The following is a description of a gene set: studied in species Homo sapiens Human Gene Set: REACTOME_NERVOUS_SYSTEM_DEVELOPMENT Nervous system development, and this is the list of marker genes: RPS13, TUBB4A, HRAS, MYH11, RANBP9, CYP51A1, RPL10L, CACNB3, COL9A2 (collagen type IX alpha 2 chain), RPS27L, COL4A5, DCC, LAMB1, PRX, PIK3R2, ARHGAP35, EFNA5, DSCAM, PSMC5 (proteasome 26S subunit, ATPase 5), RPS21 (ribosomal protein S21), COL4A4, MSN, COL4A2, MAGOHB, EPHA5, RPL27A, TRPC7, RPS24, PSMB6, COL6A1, DNM3, TUBA8 (tubulin alpha 8), RPL41, RPL18, SRGAP1, AKAP5, PSMB4, KALRN (kalirin RhoGEF kinase), PAK2, FAU, UNC5D, EPHB1, SHC3, DOK5, UPF2, SPTBN2, NUMB, TUBB2B, SEMA7A, RPS6KA2, KRAS, CUL2, EPHA3, ITGA2, CACNA1C, SH3GL2, PSMD1, CDC42, LIMK1, RPL37A, ROCK2, SCN3B (NCBI Gene Id 55800), GRB7, RPS8, DCX (doublecortin), RPL35A, EFNA1, MYH9, ABLIM1, GJB1, PPP3CB, NTN4, NRAS, RPL3, MYL6, TEAD1, NRTN, RPL27, GRIN1, CNTN2, SCN4A, FLRT3 (fibronectin leucine rich transmembrane protein 3), DSCAML1, PSMD8, ITGA5, HSPA8, SPTBN5, RPS16, PRKACB, RPL37, LHX2, AGRN, RPL17, ENAH, PSMA1, RPLP1, EVL, PSENEN, CFL1, SRGAP3, RPS7, CAP1, RPL8, ITGA9, RPL28, CSNK2A2, TYROBP, RPS2 (NCBI Gene Id 6187), LYN, IRS2, PSMC3, PLXNA1, RPLP2, EPHB2, PSMA4, RPL3L, ROBO3, TUBA1C, CNTN6, SCN1A, RPL9, PRNP, YES1, CACNA1H, DLG3, DAG1, TRPC4, CDK5, EPHA4, PSMB7, PAK6, COL4A1, COL6A6, SOS1, TIAM1, DLG1, MAGOH, RPL7A, SCN11A, PIK3R1, AP2M1, PSMD3, NCBP1, EPHA7, RPL32, PSMD11, GAB2, ROCK1, MAP2K1, PSMC6, SCN2B, PRKACA, TUBAL3, GRB2, PTPRA, RPS4Y2, RPL5, ARHGEF11, TUBA4B, LYPLA2, ABLIM3, SIAH2, SOS2, DPYSL2, ADGRG6, COL9A1, SCN9A, RPS6, ANK2, EGR2, TUBA1A (tubulin alpha 1a), TUBB6, EFNA2, ARPC2, TUBA3C, AP2S1, ARHGEF12, DPYSL3, SEMA3A, CREB1, RPL22L1, MYH14, TUBB8B, TUBB3, RBM8A, ADGRV1, PRKAR2A, CSNK2B, COL6A2, PIK3CA, GFRA3, DOK1, RET, PSMB5, MAPK1, RPS11, NCBP2, LHX4, DOK4, NRP2, PRKACG, SOX10, DPYSL4, ELOC, ANK3, RPL34, PSMC4, GFRA1, FARP2, MYL12A (myosin light chain 12A), PSMB1, FRS2, ARHGEF28, CACNA1S, ARPC4, SCN4B, RGMA, UPF3B, UBA52, CHL1, MSI1, CAP2 (NCBI Gene Id 10486), RPL30 (NCBI Gene Id 6156), COL5A2, WASL, RAP1GAP, VAV2, CACNA1G, LHX3, NCAM1, EFNB1, GAB1, RPL10, TUBB4B, ACTR3, PRKCQ, SEMA3E, SEMA6D, RPLP0, PABPC1, RPL31, TRPC5, PMP22, EPHA6, DOK2, EFNA3, ERBB2, RPL13A, ROBO2, COL6A3, TREM2, TUBB1, VLDLR, KIF4B, WWTR1, TUBB8, PAK5, KIF4A, PSPN, RPL36, TRPC1, MYO9B, RPS23, PSMB2, EFNB3, PSMD6, ABLIM2, RPL26, ADRM1, RPL36AL, RHOB, SCN8A (sodium voltage-gated channel alpha subunit 8), CLTCL1, ST8SIA4, TUBB2A, COL5A1, COL2A1, SPTB, EPHB6 (NCBI Gene Id 2051), RRAS, ABL2, VAV3 (vav guanine nucleotide exchange factor 3), GPC1, NAB2, HDAC2, PSMD14, GSPT1, MYH10, EFNB2, NCK1 (NCBI Gene Id 4690), RPS15A, ARPC3, PLCG1, PSMA7, NELL2, PTPRC, CACNA1D, HOXA2, RPL29, UNC5B, RPS18, RPL39L, EPHA10, RPS4X, RPS4Y1, PSMB3, EIF4G1, ROBO1, MYL9, HMGCR, RAC1, SEMA4A, PLXNC1, COL4A3, ITGA10, RASA1, RND1, MYO10, GSPT2, CACNB2, YAP1, ANK1, SIAH1, PSMD2, PSEN2, SEM1, ARHGAP39, SHTN1, RPL35, PIK3CD, ITGA2B, CSNK2A1, RBX1, RPL13, TRPC3, EPHA8, SH3KBP1, PLXNA4, RPS20, RPS19, CXCR4, GAP43, MAPK7, MMP9, RPL4, RHOA, SCN10A, PAK4, RPS12, APH1A, RPL6 (ribosomal protein L6), RPS6KA5, NTN1 (netrin 1), CDK5R1, ARPC1A, ELOB, RPS6KA3, RPL11, TUBA4A, CASC3, NCK2, EPHB3, ETF1, ARPC1B, LDB1, SCN1B, ACTB, SEMA5A, ITGA1, CACNA1I, RPS3, RNPS1, PLXND1, SLIT2, SRC (SRC proto-oncogene, non-receptor tyrosine kinase), AGAP2, EGFR, NCAN (NCBI Gene Id 1463), RPS3A, GRB10, PFN2, FGFR1, RDX, DNM1, ADAM10, RPL10A, ZSWIM8, SDC2, TLN1, RPL22, EPHA2, UNC5A, PSMC1, SCN3A, PLXNB1 (plexin B1), EPHB4, ALCAM, NRP1, PTPN11, PSMD7, CLTC, ACTG1, SCN2A, APH1B, MBP, COL6A5, SRGAP2, RPL24, CD72, NGEF, MMP2, RPL21, RPS26, GIT1, SREBF2, PDLIM7, NRCAM, RGMB, SPTAN1, CLASP2, CLTA, KCNQ2, SPTA1, EPHA1, CNTN1, GFRA4, NAB1, EIF4A3, PIK3CB, LIMK2, RHOC, RPL12, PSEN1, ISL1, POU3F2, RPL38, RPS6KA6, ITGAV, ITGB1, HJV, RPS9, RPS10, ABL1, LAMC1, PAK1, PAK3, COL9A3, SHC1, RPS15, NCSTN, PITPNA, TRPC6, USP33, MYL12B, MAPK3, AP2A1, SDCBP, DOCK1, RPSA, DAB1, PTK2, COL3A1, RPL14, SCN7A, CXCL12 (NCBI Gene Id 6387), NEO1 (neogenin 1), RPS14, DOK6, GSK3B (glycogen synthase kinase 3 beta), SCN5A, PSMC2, RPL23A, L1CAM, RPL23, RELN, SLIT3, RPS27, RPL19, PSMA3, CNTNAP1, RPS27A, DNM2, RPL18A, CLTB, VASP (NCBI Gene Id 7408), RPL26L1, SMARCA4, SPTBN1 (NCBI Gene Id 91654), EZR, ARPC5, ITGB3, PLXNB3, DPYSL5, DRP2, LHX9, MET, COL5A3, SEMA6A, CD24, MAP2K2, RPL7, RPS28, MAG, ST8SIA2, CLASP1 (cytoplasmic linker associated protein 1), UTRN, EFNA4, LAMA2, UBB, TUBA3E, PSMD13, RPS25 (ribosomal protein S25), RPS6KA4, RPS29, UNC5C, AP2A2, RPL39, POU3F1, FES, KCNQ3, ARTN, HSP90AB1, HSP90AA1, SPTBN4, FYN, CRMP1, LAMA1, PSMA2, UPF3A, SEMA4D (semaphorin 4D), PLXNA2, CACNB1, PIK3R3, DLG4, RPL36A, GDNF, GFRA2, CACNB4, ITSN1, PFN1, TRIO, ARHGEF7, PLXNA3, GRIN2B, PRKCA, TUBA3D, SLIT1, MPZ, NFASC, PSMA6, PSMA5, AP2B1, RPS17 (ribosomal protein S17), UBC, RPL15, TUBA1B, RPS6KA1, RPS5, PSMD12, ACTR2, SCD5, PIP5K1C